The following is a description of a gene set: The chemical reactions and pathways involving phosphatidylcholines, any of a class of glycerophospholipids in which the phosphatidyl group is esterified to the hydroxyl group of choline. They are important constituents of cell membranes. Human Gene Set: GOBP_PHOSPHATIDYLCHOLINE_METABOLIC_PROCESS species: Homo sapiens, and this is the list of marker genes: PLA2G6, GDPD3, ENPP2, GPAT4, APOC1, SCARB1, MECP2, PLA2G1B, SLC44A2, MBOAT1, PLA2G5, CHAT, CHKA, PLAAT2 (NCBI Gene Id 54979), LPCAT2, PCYT1A, PLA2G2F, APOA2, PEMT, PLB1, NR1H3, SLC44A3, LCAT, CEPT1, MBOAT2, SLC44A1, CHKB, PNPLA7, LIPC, ABHD3, PLA2G15, LPCAT3, OC90, FABP3, PLAAT4, CETP, RAB38, LDLR, PNPLA8, PNPLA6, PLA2G4C, CAPN2, PLA2G3, MBOAT7, ABHD4, APOA1, ABCA3, PLA2G4B, DBI, SLC44A5, LPGAT1, LPCAT4, LPCAT1, APOA4, PLA2G2C, PLA2G2E, PLA2G2A, PLA2G7, TMEM86B, PLAAT3, PLA2G2D, GPLD1, PLAAT1, SLC44A4, PLA2G4A, PLA2G10, MFSD2A, FABP5, PNLIPRP2, NR1H2, CDS1, PCYT1B, PON1, CHPT1, ACSL3